Given this list of marker genes Tmem87a, Kcnk4, Cacnb3, Kcna1 (NCBI Gene Id 17205), Kcnk2, here is a description of the gene set: The series of events involved in the perception of touch in which a mechanical stimulus is received and converted into a molecular signal. Mouse Gene Set: GOBP_DETECTION_OF_MECHANICAL_STIMULUS_INVOLVED_IN_SENSORY_PERCEPTION_OF_TOUCH studied in species Mus musculus